The following is a description of a gene set: Human Gene Set: GOBP_SHORT_TERM_MEMORY species: Homo sapiens The memory process that deals with the storage, retrieval and modification of information received a short time (up to about 30 minutes) ago. This type of memory is typically dependent on direct, transient effects of second messenger activation., and this is the list of marker genes: RCAN1, SERPINF1, MDK, SLC2A4, CALB1, ADNP, BRINP1, CHRNA7, PTCHD1, NPAS4, LCN2, RCAN2, CUX2